Given this list of marker genes Klf7, Edrf1, Ccnd2, Lif, Lta, Cdk6, Hsp90ab1, Runx3, Psmb7, Atp2c1, Manf, Hsp90b1, Rexo2, Tap2, Hspa8 (NCBI Gene Id 69197), Pdia3, Trgc1, Cish, here is a description of the gene set: Mouse Gene Set: CUI_ILC_IL2_RESPONSE_UP from publication Cui A, Huang T, Li S, Ma A, Pérez JL, Sander C, Keskin DB, Wu CJ, Fraenkel E, Hacohen N (PMID 38057668) Genes positively differentially expressed in cell type: ILC (innate lymphoid cell) upon treatment with cytokine: IL-2 in mouse lymph nodes in vivo. Cytokines mediate cell-cell communication in the immune system and represent important therapeutic targets. A myriad of studies have highlighted their central role in immune function, yet we lack a global view of the cellular responses of each immune cell type to each cytokine. To address this gap, the authors created the Immune Dictionary, a compendium of single-cell transcriptomic profiles of more than 17 immune cell types in response to each of 86 cytokines (>1,400 cytokine-cell type combinations) in mouse lymph nodes in vivo. A cytokine-centric view of the dictionary revealed that most cytokines induce highly cell-type-specific responses. For example, the inflammatory cytokine interleukin-1β induces distinct gene programmes in almost every cell type. A cell-type-centric view of the dictionary identified more than 66 cytokine-driven cellular polarization states across immune cell types, including previously uncharacterized states such as an interleukin-18-induced polyfunctional natural killer cell state. species: Mus musculus